Given this list of marker genes P2rx3 (purinergic receptor P2X, ligand-gated ion channel, 3), Crh, Deaf1, Mdk, Col6a1, Lrp11, Ankfn1, Scn9a, Ret, Tacr1 (NCBI Gene Id 21336), Lpar5, Scn10a, Spire1, Ephb2, Penk (NCBI Gene Id 18619), Adam11, Nmur2, Slc1a1, Pde8b, P2rx2, Mecp2, Dpp4, Htr1a, Scn3a, Osm, Ucn, Cck, Capn2, Lypd1, Adcyap1 (adenylate cyclase activating polypeptide 1), Morc1, Atp1a2, Kctd16, Zfp212, Pten, Vdac3, Ncam1, Dbh, Mtor, Trpa1, Mapk8ip2, P2rx4, Apoe (NCBI Gene Id 11816), Tmem74, Adrb1, Thbs1 (thrombospondin 1), Cacna1b, Comt, Nr2e1, Prkcg, Hmgcs2 (NCBI Gene Id 269467), Trpv1, Htr7, Ntrk1, Vwa1, Ednrb, Vdac1 (voltage-dependent anion channel 1), Grin2b, Hdac5 (histone deacetylase 5), Gch1, Npy2r, Brinp1, Esr2, Asic4, Tac1, Nr4a2 (nuclear receptor subfamily 4, group A, member 2), Prkar1b, Fbxl20, Gria1, Htr2c, Eif4g1, Mef2c, Asic1, Reln, Gja1, Grik1, Umod, Runx1, Large1, Gng7, Ido1, Rag1 (recombination activating 1), Bcl2, Nos1, Neurod2, Dbi, Cacna1e, Slco1b2, Drd4, Atat1, Slitrk4 (NCBI Gene Id 245446), Ext1, Grp, Selenon, Akt1, Gabra5, Adra2a, Gja4, Kcne2, Slc6a2, Thbs4, Als2, Grik2, Scn11a, Hcn1, Shank3, Grpr, Git2, Ppp3ca, Cacna1a, Kcnip3, D130043K22Rik, Grm7, Calca, Eif4e, Pirt, Usp46, Npas2, Drd1, Atp1a3, Cckbr, Bdnf, Taar4, Aqp9, Tspo, Crhr1, Cntnap2, Rps6kb1, here is a description of the gene set: Mouse Gene Set: GOBP_MULTICELLULAR_ORGANISMAL_RESPONSE_TO_STRESS species: Mus musculus Any process that results in a change in state or activity of a multicellular organism (in terms of movement, secretion, enzyme production, gene expression, etc.) as a result of a stimulus indicating the organism is under stress. The stress is usually, but not necessarily, exogenous (e.g. temperature, humidity, ionizing radiation).